The following is a description of a gene set: Human Gene Set: GOMF_VINCULIN_BINDING species: Homo sapiens Binding to vinculin, a protein found in muscle, fibroblasts, and epithelial cells that binds actin and appears to mediate attachment of actin filaments to integral proteins of the plasma membrane., and this is the list of marker genes: CTNNA1, SORBS3, RTCB, DAG1, SYNM, DMD, PXN, NRAP, ACTN1, TLN1, CORO2B, UTRN